Given this list of marker genes C19orf38, HSD17B12, BOP1, OSBPL9, FAM241B, HYCC1, PHGDH, KICS2, COBL, ANAPC11, CWC15, E2F2, TRIM21, ANP32B, MXD3 (MAX dimerization protein 3), NSUN7, CCDC92, MOB3C, TENT4A, NAAA, PDX1, LGALS8, COX5A, IL4R, SH3BGRL3, HLA-G, SNAI3, GNA14, LAMA5, LARP1, HOXA5, JUND, E2F8, IDH3A, TMEM41B, KCNN4, NAA20, CRLS1, WARS1, UBASH3A, NFKB1, GALNT10, PDE3B, STAT1, PSME1, MESD (NCBI Gene Id 23184), S1PR1, DCAKD, WDR64, ERMP1, STYK1, DUSP22, E2F6, TES, YRDC, COQ7, CSF1, RCBTB2, FBXO17, NEFH, MRS2, COL23A1, MRPS34, CCDC116, BSPRY, KIF14, KIF4A, NSD3, SOCS1, ZNF565, CDC6, NIPA1, CRLF1, ACSL5 (acyl-CoA synthetase long chain family member 5), DGKH, ZMIZ1, NAP1L1, HNRNPK, UBE2L6, ANKRD44, B4GALNT4, GUSB, STMN1, POP7, RWDD1, SEC24D, DSC2, MEMO1, MAPK6, FST, TMEM51, TRIM14, FIRRM, PCLAF, TMEM37, SRBD1, GAB2, ORC6, BCAN, NUP54, DGAT2, NEK4, PIGZ, NEDD4L (NCBI Gene Id 93998), CNTROB, VSIG10L, NHP2, KCTD12, NEDD4, HPSE, SORL1, PRIM2 (DNA primase subunit 2), SCNN1B (NCBI Gene Id 6338), NLRP14, B3GALT5 (beta-1,3-galactosyltransferase 5), IL10RB, PBDC1 (NCBI Gene Id 51260), KIFC1, TF, NEK7, SPRY2 (NCBI Gene Id 10253), SLC24A3, ZFP36, MFSD6, ZBTB11, KIF2C, IGFBP6, PRELID2, WNK1, PDE9A, BOD1, DKKL1, GSR, DCUN1D2, NFYA, NKIRAS2, BUD13, PKP4, UBE2C, CGAS, CACTIN, OTOS, SHISA2, CYFIP1, STARD4, SLFN13, FHIP1B, TMEM71, TMEM165, RAP2A, MRPL14, CDC42SE1 (NCBI Gene Id 56882), ST14, ATP8A2, MTMR3, ABRACL, SAPCD1, RPE, NEB, KIF23 (NCBI Gene Id 981), ING5 (NCBI Gene Id 84289), CD226, EWSR1, MRM3, ENO1, MRPL42 (NCBI Gene Id 64974), KLHL42, ATL2, TTC39C, ZBTB8A, CKLF, FOXC2, ACTR3B, TBPL1, VTI1B, CAPN2, FADS2, NAA38, NDUFA9, NR1I2, DUSP1, MLKL, LRRC59, RRS1, SH3BP2, PXYLP1, PCMT1, ICOSLG, ASF1B, PRR11, H2AX, SELPLG, SLPI, SEPTIN10, MYL6, SLC35D2, ANGPTL4, ATP23, CENPJ, SLC15A4, here is a description of the gene set: Human Gene Set: GSE14308_TH1_VS_TH17_UP Multipotential naïve CD4+ T cells differentiate into distinct lineages including T helper 1 (Th1), Th2, Th17, and inducible T regulatory (iTreg) cells. The remarkable diversity of CD4+ T cells begs the question whether the observed changes reflect terminal differentiation with heritable epigenetic modifications or plasticity in T cell responses. We generated genome-wide histone H3 lysine 4 (H3K4) and lysine 27 (H3K27) trimethylation maps in naïve, Th1, Th2, Th17, iTreg, and natural (n)Treg cells. We found that although modifications of signature cytokine genes (Ifng, Il4, and Il17) partially conform to the expectation of lineage commitment, critical transcription factors such as Tbx21 exhibit a broad spectrum of epigenetic states, consistent with our demonstration of T-bet and IFN-gamma induction in nTreg cells. Our data suggest an epigenetic mechanism underlying the specificity and plasticity of effector and regulatory T cells and also provide a framework for understanding complexity of CD4+ T helper cell differentiation. species: Homo sapiens Genes up-regulated in comparison of Th1 cells versus Th17 cells. from publication Wei G, Wei L, Zhu J, Zang C, Hu-Li J, Yao Z, Cui K, Kanno Y, Roh TY, Watford WT, Schones DE, Peng W, Sun HW, Paul WE, O'Shea JJ, Zhao K (PMID 19144320)